The following is a description of a gene set: studied in species Homo sapiens Human Gene Set: GOBP_POSITIVE_REGULATION_OF_INTERLEUKIN_10_PRODUCTION Any process that activates or increases the frequency, rate, or extent of interleukin-10 production., and this is the list of marker genes: CD46, IL13, FCER1G (NCBI Gene Id 2207), IL12B, MIR145, LILRA5, RBM47, PIBF1, IL21, LGALS9, PYCARD, STAT3, IL20RB, CD40LG, IL23A, IL6, BCL3, HGF, CD274, HMGB1, CLEC7A, TNFSF4, TUSC2, SYK, CD28, TSLP, XCL1, ISG15, TLR9, PRKCZ (NCBI Gene Id 5590), TREM2, HSPD1, SASH3, INAVA, TLR4, CD83, IL4, RAD21, IRF4, PLCG2, NOD2, F2RL1, TIGIT